Given this list of marker genes Fgd5, Dync1i1, Def6, Arhgef19, Pard6a, Prex1 (phosphatidylinositol-3,4,5-trisphosphate-dependent Rac exchange factor 1), Tnfaip1, Spc24, Bcr, Arhgef1, Spata13, Rhod, Arhgef7, Dock9, Fam83b, Syde1, Sos2, Maco1, Mospd2, Arhgap27, Tubb2a, Cyba, Cenpp, Net1, Rhoj, Diaph2, Muc13 (NCBI Gene Id 17063), Cct6a, Fam91a1, Samm50, Vrk2, Garre1, Plin3, Prex2, Rasgrf2, Cenph, Pak2, Arhgap15, Abcd3, Arhgap19, Noxo1, Rac1, Itgb3bp, Ppp2r1a, Dsg1a, Ralbp1, Ctnna1, Rab9b, Pdpk1, Nox1, Klc4, Kif5b, Nup37, Arhgap24, Cftr, Sgo1, Add3, Cdca8, Whamm, Ubxn11, Kif5a, Baiap2, Dlg5, Wasf3, Wasf1 (WASP family, member 1), Rhpn1, Ppp2r5e, Ywhag, Ccdc88a, Nup160, Rhobtb1, Arap3, Nup98, Myo19, Cavin1, Ppp1cc, Picalm, Scfd1, Clip1, Tuba1c, Stom, Mad1l1, Arhgef15, Erbin, Src, Tmem87a, Mylk, Dsp, Nckap1, Calm2, Slitrk3, Actg1, Nsl1, Fam13a, Cenpt, Mtmr1, Nck2, Clasp2, Amigo2, Rnf20, Arhgef17, Ect2, Dvl1, Bub1b, Phip, Tjp2, Ckap4, Tfrc (NCBI Gene Id 76361), Hspe1-rs1, Cyfip1, Iqgap3, Cenpu, Jup, Mcam (melanoma cell adhesion molecule), Pik3r4, Arhgef12, Akap13, Arhgap45, Actn1, Nup85, Zwint, Myh10, Tagap, Depdc1b (DEP domain containing 1B), Cops4, Rasal2, C1qbp, Cenpk, Arhgap17, Ccp110, Arhgap22, Srf, Tax1bp3, Rangap1, Kidins220 (NCBI Gene Id 77480), Dvl2, Arhgap29, Ppp2r1b, Zw10, Nf2, Kalrn, Stam, Slc1a5, Arpc5, Ankfy1, Anln, Tex2, Arhgap30, Git1, Pak6, Vav1, Emc3, Ncoa2, Tiam2, Flot2, Dlg4, Htr7, Txnl1, Mtr, Rhot1, Arhgef3, Zfp512b, Fgd4, Myl9, Map3k11, Myh14, Arhgef18, Arhgap11a, Hspe1, Als2, Csk, Bcap31, Klc2, Mad2l1, Actr3, Lrrc1, Arhgef11, Lamtor1, Dbt (NCBI Gene Id 27987), Epha2, Rhoh, Gps1, Spdl1, Bltp3b, Ndc80, Stard13, Cenpe, Lmnb1, Cdc42ep1, Fam169a, Sptan1, Swap70, Arhgap12, Stk10, Klc3, Calm3, Hmox2 (heme oxygenase 2), Pik3r3, Hnrnpc, Nhs, Ncf2, Vav3, Ercc6l, Dock7, Srgap1, Nup107, Lin7b, Arhgap9, Cdc37, Pfn2, Arl13b, Dock10, Cct7, Arpc1b, Mrtfa, Arhgap6, Ndel1, Arhgap21 (Rho GTPase activating protein 21), S100a9, Ralgapa1, Tubb4b, Abl2, Rtkn, Pik3r2, Osbpl11, Dync1li1, Sh3rf1, Cenpl, Arhgef5, Lck, Ckap5, Kif2a, Farp1, Arhgdia, Nuf2 (NUF2, NDC80 kinetochore complex component), Arhgap4, Rnd1, Arhgef9, Cenps, Ska1, Kif14, Ppp2r5a, Spc25, Ptpn13, Pard6b, Ncf4, Cdc42ep4, Farp2, Dync1h1, Filip1, Wdr11, Ctnnb1, Pkn3, Ywhae, Mapk14, Usp9x, Ocrl, Arhgap31 (NCBI Gene Id 80655), Plekhg3, Tubal3, Ncf1, B9d2, Cep97, Ckb (creatine kinase, brain), Srrm1 (serine/arginine repetitive matrix 1), Stmn2, Rock2, Kif18a, Nudc, Mapk1, Gmip, Ywhab, Emd, Arhgap26, Pkp4, Limk1, Ppp2r5d, Arhgef28, Nckap1l, Flot1, Baiap2l1, Arhgap39, Ywhah, Jag1, Cenpm, Bub1, Tuba1b, Tpm4, Fgd1, Ppp2ca, Lrrc41, Cenpc1, Pkn1, Abi1, Rps27rt, Hsp90aa1, Ktn1, Arhgap1, Sos1, Rhoa, Fgd3, Nup43, Git2, S100a8, Dock4, Plekhg5, Mcf2l, Cdc42bpb, Ppp2r5b, Arap1, Pkn2, Dock1, Aldh3a2, Kctd13, Mfn2 (NCBI Gene Id 170731), Mtx1, Tmod3, Syde2, Myo9b, Pik3ca, Steap3, Grb7, Ppp2r5c, Ranbp2, Pde5a, Cul3, Rab9, Aurkb, Dynll1, Clasp1, Spen, Iqgap1 (IQ motif containing GTPase activating protein 1), Dsg2, Ndufa5, Plxnb1, Mfn1, Rhobtb3, Abi2, Fgd2, Plekhg6, Golga3, Tra2b, Arhgap20, Dlc1, Stip1, Zwilch, Pik3r1, Stbd1, Peak1, Cops2, Srgap3, Myh9, Mcf2, Pafah1b1 (NCBI Gene Id 94322), Fam13b, Wasf2, Baiap2l2, Arpc4, Dock2, Fermt2, Arhgap10, Grb2, Ppp1r12a, Arap2, Myo9a, Actb, Bub3, Ndufs3, Fmnl2, Golga2, Wwp2, Esyt1, Dst, Myo6, Actr2 (actin related protein 2), Basp1, Vangl2, Arhgap42 (Rho GTPase activating protein 42), Nde1, Nsfl1c, Arhgef2, Pfn1, Arpc2, Sh3bp1, Acbd5, Cdc20, Hint2, Cdc42, Rac3, Rhobtb2, Kntc1, Cdc42bpa, Rapgef1, Arhgap8, Taok3, Flna, Vav2, Wipf3, Ykt6, Myl12b, Daam1, Mapk3, Nox3, Gja1, Gfod1, Stard8, Ptk2, Msi2, Arhgap25, Myl6, Frs2, Racgap1, Arhgef39, Dvl3, Abr, Tubb4a, Rcc2, Rbmx, Dock11, Vangl1, Faf2, Atp6ap1, Cpsf7, Arhgdib, Noxa1, Ar, Senp1, Taok1, Arhgef25, Slitrk5, Sptbn1, Arhgap33, Akap12, Pgrmc2, Brk1, Plekhg1, Rhot2, Pmf1, Mpp7, Gopc, Tpm3, Pld2, Armcx3, Ywhaq, Snap23 (NCBI Gene Id 98773), Arhgef6, Arpc3, Cdc25c, Stx5a, Rbm39, Chn2, Hgs, Actc1, Rhog, Rps27, Rhob, Prc1, Arhgap23 (Rho GTPase activating protein 23), Xpo1, Vapb, Arfgap3, Rhou, Cyfip2, Arhgap32, Sgo2a, Plxnd1, Tmem59, Cenpn, Btk, Ngef, Pak5, Cltc, Fnbp1, Pak3, Nck1, Nup133, Plekhg2, Arhgef10l, Rab7, Slc4a7, Rhpn2, Ddrgk1, Trak1, Fmnl1, Cenpq, Ptk2b, Trak2, Arpc1a, Prkcd, Tuba8, Tubb3, Vcp, Cav1, Tuba4a, Chn1, Prag1, Cenpa, Rras2, Dsn1, Abl1, Rnd3, Dnmbp, Trio, Cdc42ep2, Wipf1, Twf1, Pak4, Rhof, Dync1li2, Nckipsd, Plxna1, Tubb2b, Ccdc115, Aaas, Obscn, Ophn1, Elmo2, Cenpf, Srgap2, Prkcz, Iqgap2, Kif2b, Stk38, Pin1, Rhov, Nisch, Vim, Rbbp6, Ahctf1, Pak1, Zap70, Itsn2, Letm1, Ankle2, Sfn, Sema4f, Ppp1r14a, Ddx39b, Rnd2, Prkcb, Fmnl3, Arhgap40, Itgb1, Diaph1, Arhgap28, Dynll2, Tuba1a, Arhgap44, Cpd, Ankrd26, Evl, Arhgap5, Sec13, Pik3c3, Scai, Scrib, Arhgap35, Cenpo, Vamp3, Seh1l (SEH1-like (S. cerevisiae), Cpne8, Arhgap18 (NCBI Gene Id 73910), Ppp1r12b, Lman1, Vhl, Tuba3b, Efhd2, Itsn1 (intersectin 1 (SH3 domain protein 1A)), Rhoc, Stam2, Shmt2, Cenpi, Calm1, Trip10, Ppp2cb, Kif2c, Men1, Arhgdig, Dock8, Diaph3, Arhgef10, Mis12, Tor1aip1, Nipsnap2, Ppp1cb, Myh11, Fam135a, Capzb, Hsp90ab1, Arhgef16, Dock6, Pcdh7, Dock5, Cybb, Arhgef26, Mapre1, Dync1i2, Tubb6, Cdc42ep3, Slk, Mapk11, Sowahc, Lbr, Tubb1 (tubulin, beta 1 class VI), Rhoq, Cct2, Epsti1, Ska2, Frs3, Rock1, Incenp, Ccne1, Gna13, Plk1, Klc1, Wdr6, Ywhaz, Rac2, Tuba3a, here is a description of the gene set: Signaling by Rho GTPases, Miro GTPases and RHOBTB3 Mouse Gene Set: REACTOME_SIGNALING_BY_RHO_GTPASES_MIRO_GTPASES_AND_RHOBTB3 species: Mus musculus